The following is a description of a gene set: studied in species Homo sapiens part of: RHO GTPase cycle RHO BTB family belongs to atypical RHO GTPases, which are characterized by the absence of GTPase activity. RhoBTB family includes RHOBTB1 and RHOBTB2. RHOBTB3 is sometimes classified as the third RhoBTB family member, but it is divergent from the other two RHOBTBs and from Rho GTPases in general. RHOBTB1 is a component of a signaling cascade that regulates vascular function and blood pressure. RHOBTB2 is involved in COP9 signalosome-regulated and CUL3-dependent protein ubiquitination. Reactome Pathway: RHOBTB GTPase Cycle, and this is the list of marker genes: PDE5A, PHIP, CDC37, MSI2, HSP90AB1, TWF1, COPS2, CCT2, DDX39B, CCT7, MYO6 (myosin VI), RBMX, HSP90AA1, STK38, CCT6A, ROCK1, SRRM1, ACTG1, GPS1, HNRNPC, RHOBTB2, COPS4, RHOBTB1, ROCK2, TRA2B, RBBP6, CUL3, ACTN1, TMOD3, CPSF7, RNF20, VIM, TXNL1, SPEN, DBN1